The following is a description of a gene set: species: Homo sapiens Removal of the transcription factor SAP1a member of the Ternary Complex Factor (TCF) group of transcription factors which in conjunction with Serum Response Factor (SRF) has been shown to have a profound effect on positive selection in the thymus. When another TCF Elk1 is knocked out in mice there is no effect on positive selection unless it is on a Sap1a KO background where the phenotype is very severe. We have stimulated isolated double positive T cells (DPs) with anti-CD3 to mimic positive selection and compared basal and stimulated transcription across the four genotypes to discover the downstream targets of Sap1a involved in positive selection. Human Gene Set: GSE21546_UNSTIM_VS_ANTI_CD3_STIM_DP_THYMOCYTES_UP from publication Costello P, Nicolas R, Willoughby J, Wasylyk B, Nordheim A, Treisman R (PMID 20554967) Genes up-regulated in double positive thymocytes: untreated versus stimulated by anti-CD3., and this is the list of marker genes: REG3G, WDR11, LRP12, ARL6IP5, GDPD1, TRIM2, MYADM, FAM149B1, MGST3, RAB33B, LTBP1, BMAL1, KCTD10, AMOTL2, B3GALT2, OTUD1, AKAP6, EHD3, OPTN, PLSCR3, NAP1L2, SUSD6, SUOX, CYP3A43, CFI, FNDC5, IFI16, NUAK1, COX20, DNAAF9, PGM2L1, ADM, MIR137HG, MYRIP, PCMTD1, H2BC21, GRB10, IL13RA1, LMBRD1, SPARC, ZNF559, SLC25A14, SERPINE1, MAGEH1, ANXA2, RHBDF1, KCNMB4 (potassium calcium-activated channel subfamily M regulatory beta subunit 4), APH1B, LPAR1, LSAMP, ATP2B4, GBP3, ITFG1, RND3, FSTL1, PLEKHM3, ZNF627, WDR44, LIPT2-AS1, CCN2, ATP6V1G1 (NCBI Gene Id 9550), NPC2, SAMD9L, SCYL2, RAB2B, ZFP2, SYT17, CYP26A1, IL17D, TUG1, MMP1, MIR7-3HG, PELO, DUSP1, HTN1 (histatin 1), KIF21A, HSBP1L1, PTPN4, KRT18, ROGDI, ENSG00000267260, SWT1, LINC00592, CA11, TAGLN, H2AC6, PRKCH, LINC00847, ZNF671, THBS1, DUBR, SYT1, MAP2, FAM114A1, SLC47A1, CADPS, MKRN1, RAB27B, EXOC6B, RARB, ZNF419, ATP9A, NCOA7, ECHDC3, CHMP1B, KIFAP3, CCN1, ICA1L, CPA4, ADAM19, TSPAN11, MORC3, NMRK1, LCOR (ligand dependent nuclear receptor corepressor), PHACTR3, SCGB2A2, CPEB1, PCDHB3, DCTN4, NCOA4, ZNF606, KLC1, H3C6, SERP2, BLCAP, JPH3, HBP1, RAB6A, ATAD1 (ATPase family AAA domain containing 1), ITGB1, HIPK2, RASA1, ZCCHC12, CEBPD, H4C8 (H4 clustered histone 8), SMIM3, EMILIN3, ZFAND2A, MAP1LC3B, SSTR2, SERINC1, CALCB, SRSF12, NREP, ZNF875, STAG3L4, RAB15, EIF1B, C5orf46, ZNF177, RAB2A, CYP26B1, ZNF711, DKK2, ANTXR2, HBEGF, ULBP2, RUFY3, FN1 (NCBI Gene Id 2335), SLC35D2, OLFML3, EXOC1, OSTF1, ZNF251, ELMOD1, ATRN, SH3BP5, TGFBR1, AJUBA, PLPP6, WDR47, CAVIN1, TUBB2A, CEMIP2, LHFPL2, MYO5A, NBDY, PCDHB6, LINC00662, CHST7, CCNG2, DAAM1, FAM13B, ARMC9, HSD17B2, TJP2, FSD1L, KIDINS220, RAB4B, CD59, THAP8, CAMLG, ACOX1, SPRY1, RDH10, NAPB, SS18L1